Given this list of marker genes Ilk, Ank2, Svil, Dmd, Sdc4, Cmya5, Dag1 (dystroglycan 1), Actg1, Homer1, Krt19, Ank3, Vcl, Fxr1 (FMR1 autosomal homolog 1), Pgm5, Synm, Smpx, Trpc1, Krt8, here is a description of the gene set: Regular periodic sub membranous arrays of vinculin in skeletal and cardiac muscle cells, these arrays link Z-discs to the sarcolemma and are associated with links to extracellular matrix. studied in species Mus musculus Mouse Gene Set: GOCC_COSTAMERE